The following is a description of a gene set: species: Homo sapiens Human Gene Set: MIR186_3P Genes predicted to be targets of miRBase v22 microRNA hsa-miR-186-3p in miRDB v6.0 with MirTarget v4 prediction scores > 80 (high confidence targets). from publication Chen Y, Wang X (PMID 31504780), and this is the list of marker genes: LPP, TNRC6A, NUSAP1, SAMD10, CELF5, PABPC4, SUV39H2, DHX36, FEM1C, ZNF484, KREMEN1, ZBTB4, PLPP6, GPR37L1, ST8SIA3, CPD (carboxypeptidase D), WIF1, DOK6, RBMXL2, ARMH3, HIBCH, NAP1L1, RAB30, RNMT, CYB5D1, MAP3K9, OGA, GABRG2, SQOR, ATRX, ARHGAP5, BCL9, RAD54L2, LRRC41, GLS, PDCD4, BTBD1, TNKS1BP1, CCDC83, RNFT2, BCOR, PRKAA2, CD52, BCAR3, EGR2, UBE2Q1, DIPK2A (NCBI Gene Id 205428), FOXO4, TAL1, ACBD3, MEX3A, TRIM59, EIF4A2, CTNNA3, RAB11FIP1, MACC1, MAN2A1, SMCR8, TPM4, INSR, CACNB2, MARCHF6, GK5, TMX3, PUM2, EGR4, SRL, CARF (NCBI Gene Id 95855), CRAMP1, CDK1, CHEK1, AZIN1, PAPPA, HEG1 (NCBI Gene Id 57493), ST3GAL2, VIRMA (vir like m6A methyltransferase associated), NTN5, MGME1 (mitochondrial genome maintenance exonuclease 1), GABRA2, PPP2R2B, ATP2B2, HMBOX1, UBE2E3, CLEC3A, MYCBP, SP1, FOXP2, RALGAPB, DUSP3, LDB3, ADAR, GALNT7, ATXN1L, CALHM5, VSTM2B, CTCF, IL2RA, B3GALNT2, FAM117B, ADIPOR2, PBX1, WNT11, ZC3H12B, UBE2E2, MYB, CMTM4, VEZF1, HOXD11, PHLPP1, SNX30, AP2M1, CYP20A1, EFTUD2, VPS4B, C4orf19, PRKACB, CHRNB1, CNNM1, CCR9, TDRD9, PMAIP1, KDM2A, KANSL1L, PDZD7, SOCS6, FAAP20, SH3RF1, RICTOR, SLC38A1, SELPLG, GK, UVRAG, WSB2, BCL6, NFIA, MEX3C, TGDS, SYT11, HLCS, LIN54, ELAVL4, CROT, B4GALT5, LPGAT1, ANKIB1, KCNB1 (NCBI Gene Id 3745)